The following is a description of a gene set: Congenital abnormal hair pattern Human Gene Set: HP_CONGENITAL_ABNORMAL_HAIR_PATTERN A congenital abnormality of the distribution of hair growth. studied in species Homo sapiens, and this is the list of marker genes: H1-4, DOCK7, MKRN3, LRPPRC, NSUN2, GNB2, PEX1, RPS24, MYO18B, ALG11, GMPPA, RPS26, STT3A, RPL9, MED27, TFAP2A, AEBP1, FREM2 (FRAS1 related extracellular matrix 2), RBL2, SLC25A24, HS2ST1, NELFA, MAN2B1, NAA80, DPM2, POLR1B, CDH1, FLNA, ANKRD11, JARID2, ARID1A, PEPD, STAMBP, EP300, MADD, TCF12, CNOT3, SYT1, CAMTA1, DOCK6, POLR1D, SPEN, CREBBP, SOS2, PIGK, RASA2, AFG2B, TBC1D20, RPL18, DHX30, POLA1, HYOU1, DLX4, PEX19, ASXL1, CBL, H3-3A, SMARCA4, COG5, HRAS (HRas proto-oncogene, GTPase), YY1, ALG9, THOC6, SMPD4, TBX2, RAD21, SETD5, PPP1R13L, CLCN3, CCDC22, RPS28, ABCC9, ALG12, RAB3GAP1, NOTCH3, KCNN3, SOS1, PWAR1, RERE, PPP1CB, SH2B1, KRT85, KCNJ8, USB1, NANS, RPS7, SETD2, PRDM13, PIK3C2A, FGFR2, STAG2, VPS51, MAGEL2, MEIS2, FGFR3, ASCC3, ALDOA, ARHGEF2, RRAS, RPS10, BICRA, PPP2R1A, IFIH1, OGT, PTPN11, DPF2, ALX3, WBP11 (WW domain binding protein 11), RPL11, TCOF1, ZFX, XRCC4, EDEM3, B3GAT3, LRP2, CDK13, FREM1, FKRP, HDAC8, UBAP2L, ACTB, SMARCC2, LMX1B, GNE, NBN, RPS29, EMC1, MAN1B1, MAPRE2, SOX4, SOX11, PIK3CD, FILIP1, TRIO, KDM6A, TRPM3, APC, SLC35C1, CDK5, BRAF, LMNA, BRCA1 (BRCA1 DNA repair associated), PIGA, KMT2A, KCNH1, MAFB, ARID2, BSCL2, CAVIN1, NOTCH2, TRAF7, WRN, EBF3, PACS1, MAPK1, MYH3, SRY, RPS19, HDAC4, CHST3, IFT140, SMARCE1, SMO, INTU, WASHC5, SPRED2, RPS17, SALL4, KDM1A, TAF6, RPL15, CWC27, TECPR2, FGFRL1, VPS33A, SMARCB1, EFEMP1, CCNK, TBC1D24, SCNM1, SATB1, HSPG2, HEATR3, SMC1A, MEGF8, ARID1B, SVBP, RPL26, BRD4, FRMPD4 (FERM and PDZ domain containing 4), TTC5, SF3B4, CAPRIN1, SPRED1, PWRN1, MEOX1, LZTR1, SLC32A1, FOS, TSC1, TSR2 (TSR2 ribosome maturation factor), KNSTRN, RPS27, VPS13B, NSD1, SRCAP, SLC26A2, FOXP1, KRAS, RPL35A, TWIST1, APC2, SLC9A7 (solute carrier family 9 member A7), RIT1 (Ras like without CAAX 1), SNORD115-1, RPS20, PEX6, INSR, ERMARD, TBL1XR1, UBR1, KDM4B, HNF1B, SMARCD1, NF1, RAB18, PHF8, TRMT10A, COG7, ZIC1, DPH2, SHOC2, SIN3A, POLR1C, CNTNAP2, ADA2, MID1, GDF3, ACTG1, RPS15A, H4C5, RPL35, NUDT2, PPP2R3C, CDC42BPB, KMT2D, NIPBL, GDF6, SMARCA2, RPL31, RPL8, IGF1, MED12, CAV1, ARX, MED13L (NCBI Gene Id 23389), UBE2A, FRMD4A, MBD5, CPLX1, HERC2, SPECC1L, GDF11, ZC4H2, DEAF1, FGD1, ERI1, NSD2, NFIX (NCBI Gene Id 4784), UGP2, MRAS, FBXO11, TWIST2, PRKD1, NPAP1, SLC12A6, RPL5, LETM1, FAT4, TCF4, PPP1R15B, ZNF699 (NCBI Gene Id 374879), MAB21L1, TBX15, RALGAPA1, RAB3GAP2, ANKRD17, WNT4, ALX1, CTBP1, PIGG, XYLT2, MAP2K1, IRX5, EFNB1, CIT, PPARG, RHOBTB2, ADNP, CTCF, NOVA2, PGAP1, CHRNG, CDH2, RPL27, MAP2K2, NRAS, LIG4, ATP6V1B2, FRAS1, GATA1, HUWE1, CHN1, RRAS2, RAF1, AIFM1, ASH1L, CAMK2A, CPOX, SMC3, SNORD116-1, ADARB1, AGPAT2, MAP3K7, TMCO1, KREMEN1, NEPRO, SPOP